The following is a description of a gene set: studied in species Homo sapiens Pathway Definition from KEGG: (CENPF,BUBR1) == CENPE == microtubule Human Gene Set: KEGG_MEDICUS_REFERENCE_KINETOCHORE_MICROTUBULE_ATTACHMENT Kinetochore microtubule attachment. Pathway ID: N01535. Pathway type: Reference. Pathway class: nt06515 Regulation of kinetochore-microtubule interactions., and this is the list of marker genes: TUBB4A, TUBB6, TUBB3 (NCBI Gene Id 94749), TUBB2B, TUBB4B, TUBA1B, TUBA1C, TUBA3D, TUBA3E, CENPF (centromere protein F), BUB1B, TUBB2A, TUBA8, TUBB1, TUBA4A, TUBB, TUBB8, TUBA3C, CENPE, TUBA1A